Given this list of marker genes C8orf44-SGK3, DYNLT3, GABPA, IQGAP3 (NCBI Gene Id 128239), HYCC2, PLXDC2, BTG2, RMND5A, BBIP1, DNER, EXOC5, INO80D, UBE2D3, ACTN4, ASF1A, RBM18, LPGAT1, MAPK8, TASP1, IAPP, USP25, NAP1L5, ARL4A, SAMD5, SLC30A4, MTTP, ARFGEF3, DCBLD2, SP3, CBLN2, CALCB, DLG1, GNB4, GOLGA6L10, SERTAD2, SINHCAF, RBMS3, SYNM, VPS13C, CSMD3, TMEM67 (NCBI Gene Id 91147), PCSK5, SLC12A2, JKAMP, FOXK1, TMED7, PPP1R9A, FIP1L1, SLC1A1, MACO1, GOLGA6L9, PAX9, TMEM170B, IFT22, NFIB, EIF4EBP2, AGL, BMPR2, TEAD1, CBFB, KMT2B, RBPMS2, KLHL41, DDX5, NRG1, FXN, AGPS, ESR1, QKI, STX7 (syntaxin 7), PPP2R5E, CCDC92, PLXNA2, TXNDC15, SEC63, GYS1, INTS6 (integrator complex subunit 6), BCL7B, SLC25A4, AMOTL2, CCDC186, OAZ1, MFSD8 (major facilitator superfamily domain containing 8), MBD6, PTP4A2 (NCBI Gene Id 8073), MTDH, IQCH, BCL11A, ZDHHC9, MOB1B, SMIM14, PPP1R3A, CTAGE15, AGO1, SUOX, ZNF236, LRP6, TCHH, FSD1L, SGK3, TOB1, ATXN7L1, NANOS1, TIMM23B (translocase of inner mitochondrial membrane 23 homolog B), PTPRC, ADAM7, CNDP2, MIB1 (NCBI Gene Id 57534), ZBTB20, OSBPL8, TMEM39A, AP3M2, RC3H1, TRPC1, MARCHF1, MYRIP, NDST3, CNOT6, NAB1, FGFRL1, TNRC6B, CHST11, SLIT3, SMAD2, HMGN1, FOXP1, PTBP3, CPNE3, GORAB, TAF2, SNAP23, CEP350, RBM12, MSL2, HNRNPLL, KDM1B, CTAGE4, NDFIP2, DBP (D-box binding PAR bZIP transcription factor), GOLGA4, LPP, MAP4K3, PDS5B, FAM13A, C10orf88, XPO4, HIF1A, MBNL3, NECAP1, PHTF2 (NCBI Gene Id 57832), SCAI, ANKRD33B, CCDC6, FGFR1OP2, CKAP2L, TIMP3, NR2C2, LUC7L3, EPHA6, RNF2, DCLRE1B, NR3C1, HTATIP2, MBNL1, FOXF2, RIMKLB, HAPSTR1 (NCBI Gene Id 29035), MRTFB, VMA21, TNIK, ZNF367, OXTR, GPATCH2, DTWD2, PTAR1, RHCE, AVL9, UCK2 (NCBI Gene Id 7371), TMEM245 (transmembrane protein 245), PRKAR2B, MACC1, LEPR, PRKCB, CKS2, GOLGA6L4, CEP170, HNRNPR, PRELID2, ZMAT3, SH3RF1, TMEM168, GTF2H1, here is a description of the gene set: Genes predicted to be targets of miRBase v22 microRNA hsa-miR-302a-5p in miRDB v6.0 with MirTarget v4 prediction scores > 80 (high confidence targets). studied in species Homo sapiens Human Gene Set: MIR302A_5P from publication Chen Y, Wang X (PMID 31504780)